The following is a description of a gene set: species: Mus musculus Mouse Gene Set: GOBP_SPONGIOTROPHOBLAST_LAYER_DEVELOPMENTAL_GROWTH The increase in size or mass of the spongiotrophoblast layer of the placenta where the increase in size or mass contributes to the progression of that layer over time from its formation to its mature state., and this is the list of marker genes: Igf2 (NCBI Gene Id 16002), Phlda2, Nrk, Plac1, Tex19.1